The following is a description of a gene set: Human Gene Set: GOBP_MYOBLAST_DIFFERENTIATION species: Homo sapiens The process in which a relatively unspecialized cell acquires specialized features of a myoblast. A myoblast is a mononucleate cell type that, by fusion with other myoblasts, gives rise to the myotubes that eventually develop into striated muscle fibers., and this is the list of marker genes: NMRK2, XKR8, DDX17, FLOT2, BTG1, BCL9L, WNT3A, MEGF10, MBNL1, NOTCH1, ACTL6A, SOX8, SRF, MAPK12, SMARCB1, ANKRD2, MYF6, GPX1, TBX2, TBX3, KAT5, PLG, KLHL41, RANBP3L, MIR199A1, LGALS1, SMYD1, SDC1, ISL1, SMARCA4, RBPJ, ARID1B, GREM1, GDF3, WNT10B, BOC, CXCL9, ZFHX3, HIF1AN, BRD7 (NCBI Gene Id 29117), PLEC, REST, CCL8, PLEKHM3, MYOD1, EID2B, TRIP4, SMARCA2, SOX15, TNFSF14, PPARD, ARID2, SHH, SRA1, SMARCD3, SMARCE1, RIPOR2, SOX4, DDIT3, PLCB1, PBRM1, MSTN, ARID1A, SMARCD2, TBXT, SMARCC1, DDX5, ID3, MAPK14, TMEM182, CSRP3, JAG1, MBNL3, ZFP36L1, SMARCC2, MYOCD, MYOG, PRICKLE1, CAPN3, NRG1, SMARCD1, AKIRIN1, IFRD1 (NCBI Gene Id 95049), BMP4, IGFBP3, TGFB1, ACTL6B (NCBI Gene Id 51412), IL18, XIRP1, BCL9, ACTB, EPAS1, CMTM5, MAP3K5, MAML1, MEF2C, HINFP, PITX1, CXCL10, LRRC8A, SOX9, DLL1 (NCBI Gene Id 28514), TNF, RB1, ITGB1, IGF1, FGF6, RBM24, DPF3, PHF10, MYF5, SOSTDC1, TCF7L2, MUSTN1